The following is a description of a gene set: Mouse Gene Set: chr1H4 studied in species Mus musculus, and this is the list of marker genes: Gm5561, Ccdc121rt1 (coiled-coil domain containing 121, retrogene 1), Gm31728, Gm15423, Gm5069, Wdr26, Gm25829, Ahctf1, Fgfr3-ps, Gm6606, Sccpdh, Adss2, Gm38293, Catspere2, Mixl1, Gm24836, Gm16585, Lefty2, Cnih4, Lin9, Zbtb18, Exo1, Sde2, Smyd3, 2210411M09Rik, Mir6904, Gm8146, Gm24405, A430110L20Rik, Pycr2, Stum, Hnrnpu, Desi2, Cox20, Psen2, Akt3, Cnst, Sdccag8, Catspere1, Gm16547, Kif26b, Acbd3, Coq8a, Nvl, Mir350, Gm29856, Rbm8a2, 4930527J03Rik, Gm36536, Pld5, Gm8010, 2310043L19Rik, Becn2, B230369F24Rik, Gm8023, Dnah14, H3f3a, Gm10518, Cnih3, Gm24919, Gm34176, Gm18036, Itpkb, Degs1l, Gm26104, Lefty1, 2900069G24Rik, Gm20305, Gm8101 (predicted gene 8101), Gm38158, Gm37406, Gm38331, Spmip3, 3110062G12Rik, Cep170, Tmem63a, Rpl35a-ps2, Gm17965, Parp1, Efcab2, Kif28, Tfb2m, Cdc42bpa, Gm17966, Gm17967, Gm37336, Ephx1, Gm37486